The following is a description of a gene set: Human Gene Set: GOBP_GASTRULATION_WITH_MOUTH_FORMING_SECOND species: Homo sapiens A gastrulation process in which the initial invagination becomes the anus and the mouth forms second., and this is the list of marker genes: SMAD4, PRICKLE1, RNF2, AMOT, WNT5A, ACVR2B, ACVR1, PLPP3, NODAL, LHX1, CTNNB1 (NCBI Gene Id 1499), TENM4, FOXA2, ZIC3, TBXT, UGDH, FRS2, LRP5, NAT8B, ACVR2A, SRF, CRB2, ZBTB17, OTX2, LDB1, MEGF8 (NCBI Gene Id 90198), ETS2, GDF3